The following is a description of a gene set: The multiplication or reproduction of cells, resulting in the expansion of a cell population in the hindbrain. studied in species Mus musculus Mouse Gene Set: GOBP_CELL_PROLIFERATION_IN_HINDBRAIN, and this is the list of marker genes: Igf1, Rora, Gbx2, Psmg1, Slc6a4, Lhx5, C5ar1, Skor2, Atf5, Gli1, Gpr37l1, Smo, Cend1, Egf, Gli2, Shh, Rere, Fgf2, Zfp423